Given this list of marker genes Ndfip1, Cd81, Il18, Tnfsf4, Gba1, Men1, Arg2, Gsdmc2, Il25, Ido1, Socs5, Gata3, Stat6, Traf3ip2, Stard7, Il4ra, Ighe, Nlrp3, Prkcz (NCBI Gene Id 97193), Anxa1, Nod2, Rsad2, Fcer1a, Il6, Bcl3, Il33, Bcl6b, Ccr2, Ascl2, Dennd1b, Hlx, Myb, Ecm1, Crlf2, Muc19, Arg1, Batf (NCBI Gene Id 54359), Tbx21, Il4 (NCBI Gene Id 16189), Kmt2a, Cd74, Rara, Il27ra, Clcf1, Xcl1, Bcl6, Lilrb4a, Il31ra, Zfp35, Fosl2, Ifnb1, Irf1, here is a description of the gene set: Mouse Gene Set: GOBP_TYPE_2_IMMUNE_RESPONSE studied in species Mus musculus An immune response which is associated with resistance to extracellular organisms such as helminths and pathological conditions such as allergy, which is orchestrated by the production of particular cytokines, most notably IL-4, IL-5, IL-10, and IL-13, by any of a variety of cell types including T-helper 2 cells, eosinophils, basophils, mast cells, and nuocytes, resulting in enhanced production of certain antibody isotypes and other effects.